Given this list of marker genes NUP107, ZMPSTE24, KISS1R, NR0B1, NSMF, DCHS1 (NCBI Gene Id 8642), FGF8, KISS1, SIM1, GNRHR, NHLH2, FGFR1, CHD7, FAT4, PROKR2, WDR11, TAC3, MAGEL2, PROK2, SPRY4, IL17RD, DUSP6 (NCBI Gene Id 1848), FGF17, RNF216, DHX37, CYP17A1, HS6ST1 (NCBI Gene Id 9394), TACR3, GNRH1 (NCBI Gene Id 2796), ESR1, LMNA, here is a description of the gene set: Absence of pubertal development studied in species Homo sapiens Human Gene Set: HP_ABSENCE_OF_PUBERTAL_DEVELOPMENT